Given this list of marker genes CDH19, SH3BGRL2, ACTR10, EBF2, PLEKHG4, SLAIN1, ACTR2, DLG2 (discs large MAGUK scaffold protein 2, NCBI Gene Id 283225), PMS1, SOS1, NUCKS1, UBE2V2, CMPK1, SLC9C1, DEK, PTP4A1, SLC17A6, TOR1AIP2, AZIN1, IFT70B, GRK2, KHDRBS3, NUDT5 (NCBI Gene Id 11164, nudix hydrolase 5), SMIM14, FAM13C, C5orf24 (chromosome 5 open reading frame 24), KDM4C, MPHOSPH9, RORB, VPS26A, ALCAM (activated leukocyte cell adhesion molecule), CPE, CALCR, SPP1 (NCBI Gene Id 6696), SPTSSA, PRICKLE2, WDR76, TMEM33, SPCS2, PTAR1, DDX6 (DEAD-box helicase 6), SEC24A, PSD3, ROBO2, KLHL24, OR2L13, TMEM64, USP37, OPCML, ZNF519, DCUN1D3, CDC42SE2, HERC2, THBS2, TENT4B, BCCIP, USP34, CAB39, RPS6KA3, BZW1, FGF7, DBI, ENO2, THEMIS, RSPO3, GPR158, APC, PPARGC1A, SCYL3, FAM91A1, MYSM1, DMRT1, RNF111, MECOM, CSRNP1, PTPDC1, ZMYM5, ARHGAP44, AHR, DPYSL2, CLASP1, MVB12B, PFDN4, LRRCC1, TMEM220, GAB1, HIVEP2, CCDC50, MCU, SF3B1, CC2D2B, ZNF273, BTF3L4, TMEM47, SLC5A7 (NCBI Gene Id 60482), LRBA, LRP1B, FGF14, BTN3A2, TRIM2, CEP170, WIPF1, THAP2 (THAP domain containing 2), MIB1, RPE (ribulose-5-phosphate-3-epimerase), GPATCH2, REEP3, TMEM30B, HDAC2, USF3, FN1, CCNY, AGFG1, SYNPO2, FGL2, SYT14, ACTA1, USP51, LRP12, EEA1, NHSL1, POLDIP3, NKAIN2, DCAF13, EXOC5, ZFX, TRPV3, CEP350, TRPC1, CRABP2 (cellular retinoic acid binding protein 2), VGLL4, AKAP6, UBE2E1, KALRN, PTPRF, MORF4L2, MPL, SETD2, TAL1, BTBD10, LARP4, SEL1L, SENP6, SLC19A2, G3BP1, HOOK3, HINT3, COPB1, TTC27, PAIP2, CFHR2, SPIN4, MYCN, KCTD9, ARHGEF7, RNF19A (ring finger protein 19A, RBR E3 ubiquitin protein ligase), PPP4R3A, PRR23B, TMX3 (NCBI Gene Id 54495), GMEB1, SMNDC1, BCL2L1 (BCL2 like 1), DACT1, AQP4 (NCBI Gene Id 50660), NUP58, BTN3A1, ZNF626, DOK5, MFAP4, GMFB, FAM184A, SLC35A3 (solute carrier family 35 member A3), ELOC, EPB41L3, MIER3, PABPC5, SGCE, CDK1, GRIA1, CTBP2, OLA1, CYP26B1, ITGA4, WDFY3, UPRT, NFE2L2, FAN1, CAMTA2, PDE5A, CCNT2, TMEM65, CCDC126, TFAP4, PIWIL1, FAXC, DCAF7, SLC13A1, TENT5A, TMOD2, CFAP65, ASB9, ENDOV, FAT4, ZNF780B, HTR2C (NCBI Gene Id 3358), PLPPR4, TBC1D12, EDEM3, PPP3R1, CPEB4 (NCBI Gene Id 80315), RBM12, FAM169A, SLC4A7, NETO1, EDIL3, BMPR1B, EIF4E, RAB18, MPC1, KDM4A, MAP3K5, EID1, COL19A1, PHC3, RBM7, RWDD3, DENND1B, GTF2A1, TAOK1, HCFC2, WDR48, SNCA, TP53INP1, KLHL15, TOR1A, ITIH6, ASB5 (ankyrin repeat and SOCS box containing 5), RFX7, GOPC, ZFHX4 (zinc finger homeobox 4), ARHGAP12, YOD1, RRM2, CNOT6, MANEA, PNRC1 (NCBI Gene Id 10957), ARHGAP5, DPY19L3, PEAK1 (pseudopodium enriched atypical kinase 1), SENP7, ACTR8, RBM46, FMN1, SLC7A7, MTDH, EIF3A, CTLA4, ABCB1, HDAC9, ZFP42, POU3F1, FBXO9, GPR22, MAPK1IP1L, IREB2, TIMM21, KLF3, SLC39A8, CAPRIN1, PTCD2, FBXO30, SKAP2, HNRNPA3, MEF2D, CFAP206, TASP1, CLDN11, KCNK2, ERI1, GABRA4, RMI1, CACNB4, GPR180, SANBR, RAB2A, MSL3, ART3, CBX5, SCAF8 (SR-related CTD associated factor 8), FYB1, DNAH14, HOXA5, C2orf69, RAPGEF6, CDC23, HYCC1, ITGB6, ADNP2, INO80D (INO80 complex subunit D), KCNC2, CDC27, FOXN2, GPM6A (NCBI Gene Id 2823), GLCE, CAMSAP2, SLC6A2, TMPRSS11A, NFATC1, RAB3C, MED6, GPC4, MB21D2, PTGFRN, MCC, TMX4, RBMS3, MSX1, BCAP29, NAP1L2, SLC25A16, ZBTB10, GUCY1A2, PDLIM5, SCG2, ZNF280B, UFM1, LRRC58, PRKG1, TOR1AIP1, FGFR1OP2, ZMYM2, RLIG1, BCL11A, EEF1E1, FSD1L, STXBP5, PEX3, NETO2, FBXL3, PIK3CB, ZCRB1, C5orf47, ZNF823, CHRNA6, BHLHE22, GRIA3, KIAA0232, NUTF2, SKIL, WFS1 (NCBI Gene Id 94141), ANKRD13C, HMGCLL1, SATB1, RIF1, PIAS2, TMED2, STAM2, IDH1, BCLAF1, GJA1, CDKN2B, PLXNA4 (plexin A4), ARHGEF12, PDGFA, PPP3CA, CACNA1C, ZNF23, FGF2, ATRX, TRIM32, UNC5C, CDH8, PTPN4, TXNRD1, FSTL1, U2SURP, FPR3, CLCA4, ELL2, TMEM181 (transmembrane protein 181), SCEL, SEC14L1, BDNF, KSR2, MTSS1, TMEFF2, NTN4, PTPRA (protein tyrosine phosphatase receptor type A), IMPACT, PHF19, GDF6, NPAS3, SLITRK4, BAZ1A, THSD7A, ATL2, VGLL3, OSBPL8, ETNK1, SIAH1, EPHA5, ATP8A1, ZMYND11, STAU2, OXNAD1, CCNG2, IL1RAP, PRELID3B (NCBI Gene Id 51012), TXLNB, TPD52L1, GGPS1 (NCBI Gene Id 9453), CADM2, BLTP3B, RAB3IP, NEUROD6, NXPH2, PDCD1LG2, EML5, COPS7B, GOLGA6L9, TMEM132C, HSPA5, PICALM, ATP1A2, SLC12A2, MUC13, ZIC4, IMMP2L, FRMD3 (NCBI Gene Id 257019), AGMO, ASTN1, EXD1, PIGM, PJA2, CNR1, SATB2, BEND4 (BEN domain containing 4), PRICKLE1, SSBP3, SESN3, SLC7A14, ANTXR2 (NCBI Gene Id 118429), C18orf63, MYNN, ACYP2, ONECUT2, NRXN1, SLC25A24, KLF8, CTNND2, ARMCX1, PER3, HAPLN1, MAPK9, GTF2H3, TAFA4, TAFA2, C12orf56, SLC10A7, FBXO45, GABPB1, CBLN4, CASP8AP2, DIP2C, CBLL1, CCSER2, CHN2, PRKAR1A, MINDY2, MAP3K2, TGFBR3, RCSD1, GPR19, REEP1, ATAD1, VPS41, CNOT7, ATXN7, MED12, LRRFIP1, ZFHX3, KLF12, PHF20L1, NAP1L1, GPR137B, CCSER1, PTGS2, JADE1, SLC12A5, CXADR, NOD1, ADA2, CDC73, IFT57, HNRNPR, PPFIA2, C10orf88, RNF139, TM9SF3, CHM, EGLN1, CXCL2, SMARCA2, BRWD3, MAP7 (microtubule associated protein 7), TM9SF2, PPP1R9A, TMEM41B, AMMECR1, MIPOL1, ABHD13, MACROD2, FBXL17, ITPR2, EIF5A2, GNB4, POLR3G, NOVA1, AFF4, ALDH1L2, ASF1A, ZNF518A, GPR17, PDE4D, PCDH11X, TRPM6, POLR3A, TEAD3, IL13RA1, FBXO28, KIF13A, ANK3, CDH10, HP1BP3, NCAPG2, FRMD4B, NEK7, ASB7, ZFR (zinc finger RNA binding protein), MYEF2, ITGB1, NUFIP2, TMEM245, RALGPS2 (Ral GEF with PH domain and SH3 binding motif 2), TRAF7, KIF5C, SLC30A5, PELI1 (pellino E3 ubiquitin protein ligase 1), HSD11B1, STX16, PCDH18, RAB10, RNF138, TRAF6, CTDSPL2, NELL2, RC3H1, ZNF544 (NCBI Gene Id 27300), KHDRBS2 (NCBI Gene Id 202559), MGAT4A, MBNL3, STEEP1, GULP1, CD2AP, MAT1A, N4BP2L1, CDH20 (cadherin 20), PPP2R5E, THRAP3, TBC1D32, OTUD6B, FNIP1, TMEM170B, MBLAC2, ESM1 (NCBI Gene Id 11082), IPMK, SDC2, EXOC6, NANP (N-acetylneuraminic acid phosphatase), CNMD, CASK, SRSF11, ZC3HAV1L, FXR1, SREK1IP1, ZBTB20, MAGT1, NMT2, AQR, YTHDF3, DMXL2, PPHLN1, GOLGA7, LCLAT1, ARHGAP42, CREBBP, MAST4, SPIN1, RIMKLB, AEBP2, FZD8, ZFYVE16, EPS15, NIPBL, NAA15, HSP90AA1, HCN1, VEGFA, BICRAL, CNTLN, TTYH3, KCNH5, HTATSF1, CDK14, SEC23IP, PGAP1, DLX2, COL4A1, ELF1, PCDH9, PRTG, MLF1, CYTH1, PSMA5, ANGPTL3, ANKRD46 (ankyrin repeat domain 46), DICER1, ZNF638, PLD5, PAX3, MBNL2, CPEB2, DCAF12L1, FER, ZNF264, CIAO2A, BNIP2, LMAN1, CCDC88A, PDE3B, PHLPP1, ZNHIT6, TOPORS, PDS5B, DCUN1D5, MCEE, RPGRIP1L, SNTG1, NRXN3, MCOLN2, RIMBP2, USP14, UHMK1 (U2AF homology motif kinase 1), PNLIPRP3, here is a description of the gene set: studied in species Homo sapiens Human Gene Set: MIR7_1_3P from publication Chen Y, Wang X (PMID 31504780) Genes predicted to be targets of miRBase v22 microRNA hsa-miR-7-1-3p in miRDB v6.0 with MirTarget v4 prediction scores > 80 (high confidence targets).